The following is a description of a gene set: Genes having at least one occurrence of the motif CNGTAWNTG in the regions spanning 4 kb centered on their transcription starting sites. This matches the MSX1 transcription factor binding site V$MSX1_01 (v7.4 TRANSFAC). Human Gene Set: MSX1_01 studied in species Homo sapiens, and this is the list of marker genes: NEUROD6, MDGA1, DLL1, CDH5, ENSG00000291228, SPOCK2, SIM1, ARMH4, HABP2, RTN4RL1, POSTN, PHOX2B, GRK6, JAK3, SND1, WNT6, KDM4A, SYTL2, GAD1, PRDM9, ADAMTSL1, ZNF770, EHD4, SLC4A2, BARHL2, HOXC4, MCTS1, INHBA, CDC14A, HOXB4, CRX, FOXP2, NMU (neuromedin U), NXF1, HOXD3, UROD, IGF2BP3, SHOX2, ING3, UTP4, MORC4, ZIC1, RARB, CAP1, DNAJB4, AIG1, VAV1, PDZD2, GRIN2B, WBP2NL, RAB2A, FAM13B, TMEM59L, CBLN2, DLX5, CACNA1H, HMGN2, ARX, FOXP1, TMEM126B, EOMES, LINC00311, MAB21L1, PMP22, KCTD5, NR6A1, RREB1, DPY30 (dpy-30 histone methyltransferase complex regulatory subunit), TRERF1, SALL1 (NCBI Gene Id 6299, spalt like transcription factor 1), ELMO1, SIK3, SKIL, FOXG1 (forkhead box G1), MAML2, LPXN, ESRRA, ELL2, NDP, AFF3, SOX4, ASB5, LHX6, MITF, PCDHGC3, EBF2, MSX1, IL1RAPL1, DLX1, KRT25, TEX26 (testis expressed 26), POU4F2, EN1 (NCBI Gene Id 2019), NKX2-2, BDNF, FLNA, BCAR3, KMT2A, ADAM11, NR2F1, ZIC4 (NCBI Gene Id 84107, Zic family member 4), HOXC6, HOXA11, THUMPD2, EYA1, PIPOX, GNA13, BNIP3L, CCDC3, LIMS1, FSCN2, RBFOX1, EPHA7, DLG2, NCDN, BSPRY, CBX5, CHERP, NKX2-1, N6AMT1, C12orf42, KIF9, NPEPL1, NQO2, RUNX1T1, CCKAR, HOXB7, TP53, ELAVL2, ETV5, SPTB, CDK5, ACTA1, PLAC1, NTS, BTBD9, COL6A3, CEP41, PCDH12, BMAL1, PKHD1, ZNF532, TUT1, POU2F1, HSD3B7, VCAM1, MAB21L2, SMAD1, KCNAB1, NOG, NT5DC2, NOL4, RAP2C, HNRNPA1, GTPBP2, GPR12, COL27A1, MAP2K7 (mitogen-activated protein kinase kinase 7), CALM1, SPRY2, STMN4, DRD3, SPAG5, ARL6IP5 (NCBI Gene Id 10550), KIF1B, MPPE1, SYT9, SH3BGRL2, KCNJ2, CBFA2T2, SHKBP1, MACROH2A1, FUT11, SLC6A14, WRAP53